The following is a description of a gene set: Generalized neonatal hypotonia Human Gene Set: HP_GENERALIZED_NEONATAL_HYPOTONIA studied in species Homo sapiens Muscular hypotonia (abnormally low muscle tone) manifesting in the neonatal period and affecting the entire musculature., and this is the list of marker genes: MECP2, PEX16, PEX26, VAC14, SUCLG1, PSMD12, MTHFR, PEX10, COG4, BPTF, GDAP1, MT-TT, PEX3, ITPR1, PEX12, PEX6, MED12, ATP2B3, FIG4, SYNE1, EEF1A2, TBC1D24, ADNP